Given this list of marker genes UBQLN2, INF2, BAG3, TRIP4, LMNA (NCBI Gene Id 7816), GJB1, GDAP1, ASCC1, FIG4, ADPRS, MOCS1, SLC12A6, UBTF, PMP22, NDRG1, SURF1 (NCBI Gene Id 6834), NGLY1, RFC1, MOCS2, TYROBP, here is a description of the gene set: Human Gene Set: HP_AXONAL_LOSS species: Homo sapiens Axonal loss A reduction in the number of axons in the peripheral nervous system.